Given this list of marker genes CNR1, CDYL, NR2F1, SEMA3C, MAN1A1, STX11, GPM6A, NT5E, ID4, DACH1, DPYD, LTBP1, PRKAR2B (protein kinase cAMP-dependent type II regulatory subunit beta), ADAMTS5, PCDH17, ADAMTS1, PLXNC1, GNG11, CLSTN2, SLIT3, MDFIC, TPK1, EPHA4, TWSG1, GNAS, TUBB1, PBX1, TPBG, STK17B, PEG10, SGK1, KAT6B, TMEFF1, AUTS2, CITED1, GOLIM4, PLSCR4, DMD, SLIT2, CALCRL, SCAMP1, CFHR1, ZNF75D, PLN, VAV3, LRRN3, LIFR, KITLG, ACADL, LMO4, MAP2K5, OMD, PITX2, PTPRG, FARS2, PCDH7, SCML1, SH3GLB1, PERP, here is a description of the gene set: studied in species Homo sapiens Genes up-regulated in SaOS-2 cells (osteosarcoma) upon expression of PAX3-FOXO1 fusion protein off an adenoviral vector. The oncogenic fusion protein, Pax3/FKHR, is a more potent transcription factor relative to its normal counterpart, Pax3. Since Pax3 induced a mesenchymal to epithelial transition (MET) in human SaOS-2 osteosarcomas, we hypothesized that Pax3/FKHR would also induce a morphological change in SaOS-2 cells. We demonstrate here that Pax3/FKHR more potently induces a MET in SaOS-2 cells than Pax3. This greater potency was further evident where Pax3/FKHR, but not Pax3, induced a morphological alteration in U2-OS osteosarcoma cells. By microarray analysis, we determined that Pax3/FKHR altered the expression of gene targets in a manner quantitatively and qualitatively distinct from Pax3. Three classes of genes were identified: (i) genes induced or repressed by Pax3 and Pax3/FKHR, (ii) genes induced or repressed by Pax3/FKHR but not Pax3 and (iii) genes induced by Pax3/FKHR but repressed by Pax3. Chromatin immunoprecipitations confirmed the direct binding of Pax3/FKHR to the promoter region of several factors including cannabinoid receptor-1, EPHA2 and EPHA4. Verification of the microarray data also revealed coordinate alteration in the expression of factors involved in BMP4 signalling. Regulation of gene expression by Pax3 and Pax3/FKHR is, however, cell-type specific. BMP4 expression, for example, was repressed by both Pax3 and Pax3/FKHR in SaOS-2 cells, while in the rhabdomyosarcoma, RD, Pax3/FKHR, but not Pax3, induced BMP4 expression. Thus, our data reveal that Pax3/FKHR regulates a distinct but overlapping set of genes relative to Pax3 and that the global set of Pax3 and Pax3/FKHR gene targets is cell-type specific. from publication Begum S, Emami N, Cheung A, Wilkins O, Der S, Hamel PA (PMID 15688035) Human Gene Set: BEGUM_TARGETS_OF_PAX3_FOXO1_FUSION_UP